The following is a description of a gene set: Human Gene Set: MIR675_3P Genes predicted to be targets of miRBase v22 microRNA hsa-miR-675-3p in miRDB v6.0 with MirTarget v4 prediction scores > 80 (high confidence targets). from publication Chen Y, Wang X (PMID 31504780) species: Homo sapiens, and this is the list of marker genes: KANK4, FCRL1, PURA (purine rich element binding protein A), SLC5A12, CUL3, MTRF1L, SDF2, CCDC152, PLPP3, SERPINF1, UFSP2, ICOS, DIRAS2, DNMT3A, KMT5A, ZNF226, SLC10A7, FNBP4, PAPOLA, KLHL1, ORC4, PTPN20, RAD51B, LAMB4, SLC25A31, SLC25A30, ZFAND4, PTCHD4, RCOR3, FAM227B, LINC02693, KNG1, NR4A3, CDH11, TCF12, AGPS, RSRC1, CDK8, CHN2, ERRFI1, PLPP4, ATG4A, CDR2, CHST9, FMR1, TRIM9, STK39, MITD1, NAIP, BLOC1S2, CIMIP6, TET1, DDX3X, PPP4R3A, PITX2, TBC1D9B, ATXN1, CDKN2AIP, PRSS23, ADAM22, VWA5A, CREBRF, KCNA4, CLGN, CSMD3